The following is a description of a gene set: species: Homo sapiens Neighborhood of SMC1L1 NULL in the MORF expression compendium Neighborhood of SMC1L1 Human Gene Set: MORF_SMC1L1, and this is the list of marker genes: HNRNPA2B1, TRA2B, HNRNPA3P1, TRIM28, PARP1, XPO1, RAD23A, CBX3 (NCBI Gene Id 82756), NONO, NASP, EIF4H, SMARCA4, STARD7, SNRNP200, MCM7, SYNCRIP, MSH6, HNRNPM, G3BP2, POLE3, HDAC1, XRCC6, HNRNPAB, HNRNPU, UBA2, IFT25, GPN1, PRRC2C, ANAPC5, KHDRBS1, SLBP, GDI2, CNBP, NCL, COPS5, MSH2, CTCF, TARDBP (NCBI Gene Id 81927), BUB3, G3BP1, HNRNPD, RBMX, DDX39B, HNRNPR, SRSF1, SMC1A, UBE2L3, RRM1, NDUFS3, H2AZ1, EIF1AX, R3HDM1, DEK, CHERP, HAT1, PCNA, CCT2, USP1, SET, ICE1, ACLY, ATP5PF